Given this list of marker genes Zfp36, Jun, Dusp1, Fos, Hspa1a, Ier2, Pim1, Fosb (NCBI Gene Id 14282), Pmaip1, Neat1, Egr1, Btg2, here is a description of the gene set: Cytokines mediate cell-cell communication in the immune system and represent important therapeutic targets. A myriad of studies have highlighted their central role in immune function, yet we lack a global view of the cellular responses of each immune cell type to each cytokine. To address this gap, the authors created the Immune Dictionary, a compendium of single-cell transcriptomic profiles of more than 17 immune cell types in response to each of 86 cytokines (>1,400 cytokine-cell type combinations) in mouse lymph nodes in vivo. A cytokine-centric view of the dictionary revealed that most cytokines induce highly cell-type-specific responses. For example, the inflammatory cytokine interleukin-1β induces distinct gene programmes in almost every cell type. A cell-type-centric view of the dictionary identified more than 66 cytokine-driven cellular polarization states across immune cell types, including previously uncharacterized states such as an interleukin-18-induced polyfunctional natural killer cell state. species: Mus musculus from publication Cui A, Huang T, Li S, Ma A, Pérez JL, Sander C, Keskin DB, Wu CJ, Fraenkel E, Hacohen N (PMID 38057668) Mouse Gene Set: CUI_CDC2_IFNL2_RESPONSE_DN Genes negatively differentially expressed in cell type: cDC2 (conventional dendritic cell type 2) upon treatment with cytokine: IFN-λ2 in mouse lymph nodes in vivo.